Given this list of marker genes ALDH1A1, SLC38A1, PHGDH, ABAT, SLC1A3, ALDH5A1, GAD2, GAD1, here is a description of the gene set: The chemical reactions and pathways involving gamma-aminobutyric acid (GABA, 4-aminobutyrate), an amino acid which acts as a neurotransmitter in some organisms. studied in species Homo sapiens Human Gene Set: GOBP_GAMMA_AMINOBUTYRIC_ACID_METABOLIC_PROCESS